The following is a description of a gene set: species: Homo sapiens Confusion Lack of clarity and coherence of thought, perception, understanding, or action. Human Gene Set: HP_CONFUSION, and this is the list of marker genes: ATP13A2 (ATPase cation transporting 13A2), ALDH4A1, VPS13C, HLA-DQB1 (NCBI Gene Id 7924), IL10, MT-TE, PSEN1, ATP1A2, TLR4, HMBS, TBP, CHRNA2 (NCBI Gene Id 1135), IL23R, SLC25A13, IL12A, CCR1, MEN1, CDKN2C, TLR3, EPM2A, TOMM40, PRDX1 (peroxiredoxin 1), SORL1, ERCC2, TRANK1, CDKN1B, ERCC5, NOTCH3, FAS (NCBI Gene Id 355), ERCC4 (ERCC excision repair 4, endonuclease catalytic subunit), GNAS, APP, POLR3A, ERCC3, ABCA7, CTSF, NHLRC1, KLRC4, RYR1, FIG4, ERAP1 (NCBI Gene Id 51752), CPOX, SCN1A, SLC2A1, TTR, UBAC2, TREM2 (NCBI Gene Id 54209), CDKN2B, C4A, CUBN, IL12A-AS1, OTC, TBK1, ABCD1, PRNP, IVD (NCBI Gene Id 3712), HADH, SLC19A3, ALAD, IFNGR1, DNMT1, APOE, CDKN1A, SLC25A15, UQCRH, HLA-B, MAN2B1 (mannosidase alpha class 2B member 1), PSEN2, MEFV, PRRT2, ADAMTS13, NAGS, SLC22A5, MMACHC, CACNA1A, STAT4, PRDM8